The following is a description of a gene set: Genes predicted to be targets of miRBase v22 microRNA mmu_miR_7231_5p in miRDB v6.0 with MirTarget v4 prediction scores > 80 (high confidence targets). from publication Chen Y, Wang X (PMID 31504780) Mouse Gene Set: MIR_7231_5P species: Mus musculus, and this is the list of marker genes: Wnt9b (NCBI Gene Id 22412), Sbk3, Slc7a14, Sema5a, Nexn, Cyp4a12b, Serinc5, Zfp273, Pla2g4c, Opcml (opioid binding protein/cell adhesion molecule-like), Ino80d, Ppp1r3b, Pgm2l1, Agap2, Dsg2, Mtbp, Pgr15l, Cul3, Slc4a10, Bach2, Rab3b, Slc9a5, Luc7l3, Clock, Usp12, Steap2, Zfp219, Gmeb1, Pak5, Thbs1, Arhgef33, Bgn, Rel, Elovl2, Pcdh17, Tgm2, Smagp, Mid1, Cux1, Plaat1, Ago2, Kalrn (NCBI Gene Id 72378), Cnih3, Pif1, Pde1c, Kpna1, D630003M21Rik, Kif3b, Ube3c, Hnf4a, Tyw1, 6030458C11Rik, Tmem241, Umad1, Rnd3, Zbtb4, Nacc1 (NCBI Gene Id 70360), Cdyl2, Dmc1, Rora, Igf1, Ctdnep1, Mecp2, Plagl1, Prlr, Tom1l2, Mas1, Gnal, Kat6a (NCBI Gene Id 60407), Lcn4, Cacnb1, Pdxk, Themis, Zfp85 (zinc finger protein 85), Srpx, Perp, Scnm1, Elob, Clec12a, Scn1a, Sumo3, Slc4a8, Ccdc178, Ankrd10 (ankyrin repeat domain 10), Zmym2, Irag2, Pecam1, Xpo7, Rae1, Lgr5, Wdr55, Tram1, Napg (N-ethylmaleimide sensitive fusion protein attachment protein gamma), Pdzd4, Ssh2, Sebox, Timm10b, Hccs, Arhgap21, Pcsk6, Snrnp27, Cend1, Cfap90, Runx1t1, Six4, Crip3, Col1a1, Zbtb33, Zbtb39, M6pr, Nectin2, Bex2, Samd4b, Kcnk3, C1qtnf1, Yy1, Ms4a4c, Bcap31, Tbr1, Zc3h4, Slc1a2, Fcrla, Zfhx4, Ammecr1l, Rictor, Dock3, Flrt2, Rtp3, Aak1, Capn5, Cmtr2, Arhgef12, Fbxl17, D16Ertd472e, Zdhhc13, Sh3pxd2a, Ccdc184 (coiled-coil domain containing 184), Elavl3, Tnfsf8, Cyp4a12a, G3bp2, Crxos, Syngr2, A830018L16Rik, Dcdc2a, Mtmr2